Given this list of marker genes DNAJB1, MT1X, TXNRD1, FOSL1, BCL2, H2BC21, MT2A, MT1E, GCLM, PEX2, MT1G, MT1H, MT1B, MT1M, HMOX1, here is a description of the gene set: Human Gene Set: ZHENG_RESPONSE_TO_ARSENITE_UP from publication Zheng XH, Watts GS, Vaught S, Gandolfi AJ (PMID 12679051) Chronic, low-level exposure to arsenic frequently results in skin, lung, bladder, and kidney cancer. Since arsenic is primarily excreted via the kidney, this study focused on this target tissue. Gene array was used as a sensitive low-level monitor of the impact of arsenic on this target tissue. Arsenite was chosen as the chemical species of arsenic since As(III) species are touted as the cellular toxic form of arsenic. Human embryonic kidney cell line HEK293 cells were incubated with 1, 10, and 25 microM arsenite for 6 or 24 h. Total RNA from treated and control cells was isolated, reverse transcribed, and labeled with Cy3 or Cy5, and hybridized to a human cDNA microarray. Hybridizations were performed four times using independent total RNA preparations to ensure reproducibility. Raw data from 10 and 25 microM treated cells exposed for 6 h was normalized within, and between, hybridizations followed by identification of genes affected by arsenite exposure based on practical significance (2-fold change up or down) and reproducibility (affected in four of six measurements). In these studies, genes (HMOX1, MT1E, or FOSL1, etc.) were up-regulated, and genes (MYC, JAK1, or CENPE, etc.) were down-regulated. Genes identified at 10 and 25 microM arsenic exposure were then examined after 1 microM treatment for 6 or 24 h. Expression of affected genes showed a dose-dependent (1-25 microM) trend that was apparently not time-dependent (6 vs. 24 h). The affected genes indicate that even this realistic, low-level arsenite exposure was recognized by the HEK293 cells (e.g. metallothionein genes) and produced an oxidative stress (e.g. heme oxygenase gene). These affected genes were characterized as stress response genes, proto-oncogene, signaling molecules, transcription factors, chemokine receptors, proteolytic enzymes, ESTs, and unknown genes. These findings imply that arsenite induces complex cellular injury and the cellular adaptation to As(III) is associated with alterations in the expression of many genes. Up-regulated in HEK293 cells (kidney epithelium) by treatment with sodium arsenite. studied in species Homo sapiens